Given this list of marker genes Slc13a5, Slc5a6, Slc6a9, Slc13a2, Slc5a8, Slc6a20a, Slc10a1, Slc1a6, Slc6a7, Slc1a1, Slc6a15, Slc1a2, Slc6a14, Slc38a2, Slc1a3, Slc10a5, Slc6a5, Slc23a1, Slc6a12, Slc6a13, Slc5a12, Slc13a3, Slc10a4-ps, Slc38a7, Slc10a6, Slc38a1, Slc6a1, Slc6a11, Slc23a2, Slc6a20b, Slc10a3, Slc1a7, Slc10a2, Slc10a4, Slc6a8, Slc38a4 (solute carrier family 38, member 4), Slc6a6, here is a description of the gene set: Enables the transfer of a solute or solutes from one side of a membrane to the other according to the reaction: organic acid(out) + Na+(out) = organic acid(in) + Na+(in). species: Mus musculus Mouse Gene Set: GOMF_ORGANIC_ACID_SODIUM_SYMPORTER_ACTIVITY